Given this list of marker genes Src, Arhgef5, Rhoa, Lcp1, Hck, Fscn1, Mapk9, Mapk8, Arpc2, Tnf, Arhgef2, Csf2, Il5, Msn, Kif9, Gsn, here is a description of the gene set: species: Mus musculus Any process that modulates the frequency, rate or extent of podosome assembly. Mouse Gene Set: GOBP_REGULATION_OF_PODOSOME_ASSEMBLY